The following is a description of a gene set: Human Gene Set: HP_THORACOLUMBAR_KYPHOSIS Hyperconvexity of the thoracolumbar spine producing a rounded or humped appearance. Thoracolumbar kyphosis studied in species Homo sapiens, and this is the list of marker genes: GBA1, NEPRO (NCBI Gene Id 285338), KIF22, NPR2, CDH11, FBXO28, AMER1, MGAT2, COL2A1, MED12L, FLNB (NCBI Gene Id 8413), FGFR3, GLB1, GNPTAB, LBR, EXTL3, GUSB, SLC26A2, LHX3, MAN2B1, CCN6, POP1